The following is a description of a gene set: part of: Innate Immune System Reactome Pathway: Neutrophil degranulation species: Homo sapiens Neutrophils are the most abundant leukocytes (white blood cells), indispensable in defending the body against invading microorganisms. In response to infection, neutrophils leave the circulation and migrate towards the inflammatory focus. They contain several subsets of granules that are mobilized to fuse with the cell membrane or phagosomal membrane, resulting in the exocytosis or exposure of membrane proteins. Traditionally, neutrophil granule constituents are described as antimicrobial or proteolytic, but granules also introduce membrane proteins to the cell surface, changing how the neutrophil responds to its environment. Primed neutrophils actively secrete cytokines and other inflammatory mediators and can present antigens via MHC II, stimulating T-cells.<br><br>Granules form during neutrophil differentiation. Granule subtypes can be distinguished by their content but overlap in structure and composition. The differences are believed to be a consequence of changing protein expression and differential timing of granule formation during the terminal processes of neutrophil differentiation, rather than sorting (Le Cabec et al. 1996). <br> <br>The classical granule subsets are Azurophil or primary granules (AG), secondary granules (SG) and gelatinase granules (GG). Neutrophils also contain exocytosable storage cell organelles, storage vesicles (SV), formed by endocytosis they contain many cell-surface markers and extracellular, plasma proteins. Ficolin-1-rich granules (FG) are like GGs highly exocytosable but gelatinase-poor., and this is the list of marker genes: ORM2, GM2A, RAC1, ANXA2 (NCBI Gene Id 792), EEF1A1, PADI2, HMOX2 (heme oxygenase 2), ADA2, ALDOA, QPCT, LTF, TOLLIP, ACTR1B, SERPINB12, PTPRN2, TARM1, PSEN1, ATP6AP2, SLC2A3, S100A8, OSCAR, FCGR3B, RETN, PLD1, ADGRG3, CR1, MNDA, CSNK2B, ITGB2, PIGR, VAT1, PSMD14, AGA, CLEC4C, ITGAL, KCMF1, MMP25, ACTR2, IMPDH2, CD47, SIGLEC9, FCN1, EPX, MAPK1, BST1, PSMB7, PPIE, CAT, LILRA3, S100A11, CYB5R3, FUCA2, RAB9B, GAA, CXCR1, HGSNAT, DSG1, TOM1, PTPRC, PTX3, ARSB, STK11IP (NCBI Gene Id 114790), PSMD2, SERPINB1, CD68, B4GALT1, TRAPPC1, SDCBP, SLCO4C1, TRPM2, VAPA (NCBI Gene Id 9218), PSMA2, S100A9, PRSS3, SIGLEC14, NCSTN, AMPD3, RAB10, PSMA5, SLC11A1, C3AR1, FOLR3, HLA-H, IGF2R, RHOF, CYBB, ARL8A, PSMD13, A1BG, IST1, KPNB1, CNN2, CEACAM6, TNFAIP6, CTSS, HSPA8, LCN2, SERPINB6, CTSC (cathepsin C), PSMD11, CD63, BST2, OSTF1, SERPINB10, ARG1, DSN1, RHOA, HPSE (heparanase), CD93, ALDH3B1, TYROBP, MMP8, CYSTM1, LYZ, ITGAM, LAMP1, BRI3, CD177, CKAP4, ATP6V0A1, HEBP2, PRCP, SERPINA3, RAP2C, ALDOC, TBC1D10C, FRK, CHRNB4, RNASET2, MVP, SNAP29, PLAU, ANPEP, HP, HSP90AB1, LAMTOR1, RAB44, PYGB, AGPAT2, HMGB1, PRG3, TMBIM1, ARSA, CTSB, CLEC12A, CAPN1, DNAJC5, CEACAM3, NEU1, ATP8B4, ENPP4 (NCBI Gene Id 57011), SIRPB1, MS4A3, GSTP1, TICAM2, ARMC8, PLEKHO2, PGLYRP1, DNAJC13, RAB18, RAB7A, NFKB1, PDXK, NIT2 (nitrilase family member 2), RAB5B, STOM, DOK3 (docking protein 3), C6orf120, PFKL, PTGES2, LAMTOR2, GPR84, XRCC5, FABP5, TUBB, CXCR2, DSC1 (desmocollin 1), CTSZ, PTPRJ, MANBA, ATP11A, LTA4H, ATP6V1D, SLPI, PTPRB, PSMD3, MCEMP1, FGL2, GYG1, CXCL1, MPO, FCGR2A, RHOG, SNAP25, GSN, PRG2, GUSB (glucuronidase beta), SERPINB3, SPTAN1, COTL1, BPI, PTAFR, ATP6V0C, ARPC5, DYNLL1, RNASE2, DIAPH1, CCT8, HUWE1, NFAM1, S100A7, ATP8A1, FGR (FGR proto-oncogene, Src family tyrosine kinase), FTL, CHIT1, NDUFC2, GLIPR1, S100A12, TCIRG1, TIMP2, HSP90AA1, CD58, TUBB4B, ROCK1, B2M, VAMP8, APAF1, CYBA (cytochrome b-245 alpha chain), CTSA (NCBI Gene Id 5476), MAPK14, SLC44A2, YPEL5, CTSH, GALNS, JUP, CPPED1, TMEM30A, HSPA6, CANT1, DYNLT1, VCL, SRP14, GDI2, CREG1, CTSG, CAP1, GLA, ATAD3B, LRG1, OLFM4, CDK13, CD14 (NCBI Gene Id 929), PRDX4, ERP44, ASAH1, IMPDH1, DOCK2, SCAMP1, RAB37, DNASE1L1, CD59, RAP1A, MGST1, P2RX1, MOSPD2, HEXB, ORM1, SLC15A4, RAP2B, NCKAP1L, CEACAM8, ATG7, CALML5, RAB3D, CLEC4D, NBEAL2, TMEM179B, GGH, HSPA1A, CD55, GPI, HVCN1, PNP, AHSG, RNASE3, CD36 (NCBI Gene Id 948), NAPRT, AZU1, MIF, XRCC6 (X-ray repair cross complementing 6), TCN1, ACP3, LILRB3, ARHGAP9, CAMP, PSMD12, DNAJC3, COPB1 (NCBI Gene Id 51664), S100P, PRTN3, DBNL, MMTAG2, CEACAM1, FCAR, CRISP3, FLG2, DEFA4, HBB, CST3 (cystatin C), CFD, ITGAV, CLEC5A, PAFAH1B2, DSP, RAB4B, PPBP, ITGAX, STBD1, ADGRE5, MAN2B1, SURF4, CAB39, SYNGR1, PECAM1, FCER1G, AP2A2 (NCBI Gene Id 25955), KCNAB2 (potassium voltage-gated channel subfamily A regulatory beta subunit 2), PLAUR, PA2G4, C5AR1, ABCA13, DDX3X, ILF2, HK3, ACAA1, ALOX5, CMTM6, CPNE1, DEFA1, TMT1A, BIN2, GNS, SLC2A5, CTSD, PSMC2, SIGLEC5, HLA-C, AOC1, PSMD7, PKP1, UBR4, PDAP1 (PDGFA associated protein 1), LAMP2, RAB31, MGAM, PGAM1, ELANE, LRRC7, PTPN6, APRT, PKM, PSAP, SELL, PSMC3, HSPA1B, TMEM63A, MME, PSMD6, FTH1, RAB27A, DERA, DEGS1, VCP, EEF2, FPR2, SVIP, LGALS3, PSMD1, ADAM8, IQGAP2, CYFIP1, DYNC1H1, COMMD3, PRDX6, SERPINA1, PGM2, MMP9, IQGAP1, HRNR, TNFRSF1B, NHLRC3, RAP1B, GLB1 (NCBI Gene Id 2720), PGRMC1, DYNC1LI1, PYCARD, CAND1, CD53, ARHGAP45 (NCBI Gene Id 23526), TMC6, CRACR2A, AP1M1, LPCAT1, RAB14, ADAM10, GOLGA7, GHDC, TXNDC5, FRMPD3, AGL, TSPAN14, CD33, UNC13D, RAB6A, HLA-B, PLAC8, DDOST, FAF2, ANO6, CDA, CEP290, PYGL, PSMB1, GRN, NME2, PGM1, STK10, NFASC, ATP11B, RAB24 (NCBI Gene Id 53917), CCT2 (chaperonin containing TCP1 subunit 2), LAIR1, LAMTOR3, NRAS, ACLY, FUCA1, IRAG2, TLR2, COMMD9, ALAD, SNAP23, CRISPLD2, NPC2, STING1, CD300A, MLEC, ORMDL3, APEH, SIRPA, OLR1, RAB3A, GCA, SLC27A2, CSTB, ADGRE3, PRKCD, GMFG, ACTR10 (actin related protein 10), MAGT1, LILRB2, DGAT1, GSDMD, CHI3L1, C3, QSOX1, VNN1, DPP7, CFP, FPR1, IDH1, RAB5C, CD44, TTR, VPS35L, PPIA, KRT1, CPNE3, PRSS2